The following is a description of a gene set: Combining with a GPI-anchored ephrin to initiate a change in cell activity. Human Gene Set: GOMF_GPI_LINKED_EPHRIN_RECEPTOR_ACTIVITY studied in species Homo sapiens, and this is the list of marker genes: EPHA7, NTRK3, EPHA4, EPHA5, NTRK1, EPHA3, EPHA8